Given this list of marker genes SDCBP2, SLC12A2, EZR, TUBB, AFDN, KRT18, DSG2, MYADM, GOLM1, CLDN1, TST, SPINT2, SPP1, ANXA11, AQP3, TRNP1, TUBB4B, ANPEP, SHROOM3, PLD1, ANXA4, TPM1, ONECUT2, AKR1C2, TACSTD2, KRT8, BMP2, LRP10, OCLN, RBM47, DCDC2, S100A11, LGALS2, ANXA13, SLC4A4, MMP7, GCNT3, TSPAN3, CXCL6, TM4SF1, LGALS3, GABRP, GADD45A, GPX2, CD63, SPATS2L, ABHD2, SPINK1, GALNT4, PMEPA1, SPTBN1, ACTN4, CFTR, ERBB3, CGN, TXLNG, SLC5A1, CD24, LMNA, TPPP3, MUC5B, PDZK1IP1, RAB11FIP1, SORBS2 (sorbin and SH3 domain containing 2), WEE1, LGALS4, AQP1 (aquaporin 1 (Colton blood group)), LAMB3, ATP1B1, CLDN10, TAX1BP3, KRT7, TTN (NCBI Gene Id 7847), TPM4 (NCBI Gene Id 7171), AGR2, NQO1, DSP, SDC4, BEX3, PHLDA2, EEIG1, HSPB1, MYO1C, TAGLN2, KLF5, MLPH, CDKN1C, DDR1, ATP1A1, MUC13, BIRC3, HBEGF, MYL12B, ITGB1, CTSH, ENAH, ACTG1, RAC1, FXYD3, DEFB1, AKR1B10, MAL2, CYSTM1, CEACAM6, TUBB2A, TNFAIP2, LAD1, UGT2B15, CD151, CLDN4, LMO7 (LIM domain 7), FA2H, GSTP1, CPM, KLK11, NR2F2, EPCAM, S100A6, SPINT1, PTPRF, MUC1, TFF3, KRT19, CES1, CLU, CHP1, SOX9, CD59, CDC42EP1, TENT5A, TSPO, SOX4, CLIC1, ATF3, GTF2I, DUSP4, SLPI, NFIB, ANXA5, CAMK2N1 (calcium/calmodulin dependent protein kinase II inhibitor 1), S100A14, PIGR, ELF3, S100A10, LCN2, CAPN2, CCND1, DSTN, TMC5, NHSL3, PERP, TNFRSF12A, CAV2, MUCL3, ABLIM1, PRDX5, SLC12A7, CALM2, TSPAN8, TJP1, BACE2, TM4SF4, CRYAB, DYNC1I2, CDH1, CXCL8, MYL6, KCNJ15, VSTM2L, TNFRSF21, CHST4, CLDN3, TXN, NECTIN2, LMO4, CLDN7, CYFIP1, PPDPF, VAMP8, SGMS2, CLINT1 (NCBI Gene Id 9685), MSI2, WFDC2, VTCN1, ANXA2, here is a description of the gene set: studied in species Homo sapiens Human Gene Set: AIZARANI_LIVER_C24_EPCAM_POS_BILE_DUCT_CELLS_3 from publication Aizarani N, Saviano A, Sagar, Mailly L, Durand S, Herman JS, Pessaux P, Baumert TF, Grün D (PMID 31292543)